The following is a description of a gene set: Any process that modulates the rate, frequency or extent of a small molecule metabolic process. Mouse Gene Set: GOBP_REGULATION_OF_SMALL_MOLECULE_METABOLIC_PROCESS studied in species Mus musculus, and this is the list of marker genes: Elovl5, Pid1, Nos3, Kcnma1, Prkg2, Ces1e, Dkkl1, Myc, Snai2 (snail family zinc finger 2), Phka1, Bmp6, Apc, Il1b, Tcf7l2, Acsl5, Bmp5, Pdk4 (pyruvate dehydrogenase kinase, isoenzyme 4), Prkag2, C1qtnf3, Hmgb1, Epm2aip1, Rdh19, Prkg1, Hnf1a, Qki, Mst1, Ogt, Amdhd2, Fmo1, Cd244a, Dgat1, Dbi, Idi2, Gcg, Usp7, Tnf, Lmf1, Wdtc1, Cmtm2a, Fbp1, Pex2, Ntsr1, Plek, Ranbp2, Pou1f1, Ddb1, Mfsd2a, Eif6, Dgkq, Hdac4, Ces1h (carboxylesterase 1H), Pdk2 (NCBI Gene Id 18604), Cyp27b1, Rdh16f2, Dgat2, Sirt2, Creb1, Tmsb4x, Bcl2l1, Mapk9, Ins2, Malrd1, Gnai1, Serpina12, Pth, Ptpn2 (NCBI Gene Id 19255), Igfbp3, Lonp2, Ankrd26, Mas1 (MAS1 oncogene), Dnajc30, Npy1r, Htr2a, Mup4, Ghsr, Thrb, Rdh16, Srebf2 (sterol regulatory element binding factor 2), Ep300, Ldlr, Pth1r (NCBI Gene Id 19228), Pgk1, Nucb2, Fdps, Nfe2l1, Abcd1, Sesn2, Erlin2, Mir214, Entpd1, Por, Eno1b, Trp53, Gnb3, Flcn, Pgp, Igf2, Gprc6a, Pptc7, Igf1, Mup5, Avpr1a, Cd74, Ppp1r3g, Bckdk, Slc22a13, Slc7a7, Prkag1, Nln, Cpt1a, Rdh9, Adipor1, Fis1, Irs2, Esrrb, Ch25h (NCBI Gene Id 12642), Nr1h2, Prkn, Rdh1, Phkb, Abcg4, Egr1, Ceacam1, Nr3c1, Stard4 (NCBI Gene Id 77154), Slc27a4, Ppara, Atp2b4, Cbfa2t3, Ces1d, Gpd1, Pdk1, Bend3, Apoa1, Psen1, Myh9, Mir199a-2, Atpsckmt, Tpk1, Cd320, Akt2, Antkmt, Mlx (MAX-like protein X), Ndufc2, Erlin1, Etfbkmt, Arl2, Pfkfb1, Fmo5, Fgfr4, Lepr, Sirt1, Ubr4, Sik1, Mbtps2, Gdf15 (NCBI Gene Id 23886), P2rx7, Adck2, Trim63, Jmjd8, Nfkb1, Il6, Mlycd, Apoc2l, Fabp3, Acadvl, Supt20, Ppp1r3b, Anxa1, Actn3, Mir143, Ceacam2, Tysnd1, Comt, Cln3, Dkk3, Lcmt1, Snca, Mlst8, Apob, Ncor1, Gpld1, Foxk1, Ptafr, Apoe, Fgl1, Mtch2, Stat3, Gpt, Rptor, Oaz1, Ces1f, Phkg2, Zbtb20, Abcb11, Ttc39d, Sod1, Sox9, Appl2, Insr, Ephx2, Ptgs2, Fmo2, Gchfr, Isyna1, Slc45a3, Star, Cacna1a, Acadm, Kat2a, Atcay, Sirt7, Kat2b, Cyp2j6 (NCBI Gene Id 13110), Wdr5, Insig2, Ppargc1a, Apoc3, Apoc1, Nr1h3, Rdh10, Atp5if1, Slc4a1, Bglap, Mup2, Slc35b4, Clk2, Foxo1, Git1, Pibf1, Lhcgr, Nkx1-1, Guca1a, Uchl1, Erfe, Fabp1, C1qtnf12, Kit, Fmo4, Irs1, Mtln, Dyrk2, Cyp7a1, Sphk2, Plcd1 (phospholipase C, delta 1), Klhl25, Abcg1, Gpi1, Adcy10, Phkg1, Ces1c, Ppp1ca, Il3, Tspo, Mup3, Guca1b, C1qtnf1, Ier3, Adcyap1r1, Scp2, Mapk1, Nnmt, Dhcr7, Wnt4 (wingless-type MMTV integration site family, member 4), Brca1, Plin5, Ppp1r3e, Me1, Hnf4a, Pparg, H6pd, Isx, Mtcl2, Ttc39b, Lep, Fgf15, Gapdhs, Ins1, Gper1, Pla2g3, Adipoq, Ggcx, Arv1, Scap, Oprm1, Rora, Arpp19, Hif1a, Rgn, Prkaa1 (protein kinase, AMP-activated, alpha 1 catalytic subunit), Ces1a, Ifng, Pdk3, Mtor, Aldob, Bmp2, Acsl4, Snai1, Ppp4r3b, Mid1ip1, Acacb, Fabp5, Lpcat3, Dnm1l, Trib3, Src, Slc2a6, Twist1, Mup11, Trem2, Prox1, Sik2, Apoc2, Sec14l2, Zfp692, Ppp2ca, Avp (arginine vasopressin), Ncoa2, Park7, Sirt6, Eno1, Acmsd, Gfi1 (growth factor independent 1 transcription repressor), C1qtnf2, Nr1h4, Fh1, Cda, Il4, Dcaf5, Ces1g, Cav1, Abcd2, Clybl, Parp1, Cry1 (NCBI Gene Id 12952), Vcp, Gck, Eif2ak3, App, Ces1b, Bglap2, Prxl2c, Rd3, 3110082I17Rik, Prkag3, Mlxipl, Ppp4r3a, Me2, Obp2a, Insig1, Prkaa2, Lpgat1, Zbtb7a, Slc7a11, Acadl, Xpc, Gpr146, Sorbs1, P2ry6, Lacc1, Map2k1, Slc4a4, P2ry1, Fgf1, Prkaca, Gk, Tigar, Hsd11b1, Zmpste24, Myog, Pank2, Arnt, Agt, Adra1b, Macroh2a1, Apoa4, Sirt5 (NCBI Gene Id 69760), Srebf1, Pla2g4a, Clcn2, Gmppa, Rorc, Dab2 (NCBI Gene Id 70555), Akr1c18, Aqp8, Ppard, Foxk2, Trex1, Prmt3, Nr1d1, Nupr1, Rest, Slc25a12, Stk11, Tff3, Apoa5, Cnr1 (cannabinoid receptor 1), Pmaip1, Paqr3, Igfbp4 (insulin-like growth factor binding protein 4), Avpr1b, Mup1, Gnmt, Adora2b, Ddit4, Sirt4, Akt1, Gip